Given this list of marker genes Hnrnpa1, Shfl, Srsf4, Dhx9, Etf1, Srsf3, Rbm24, Mvk, Larp6, Nova1, Fmr1, Ssb (small RNA binding exonuclease protection factor La), Dhfr, Lin28a, Tyms, Nova2, here is a description of the gene set: species: Mus musculus Mouse Gene Set: GOMF_SEQUENCE_SPECIFIC_MRNA_BINDING Binding to messenger RNA (mRNA) of a specific nucleotide composition or a specific sequence motif.